The following is a description of a gene set: Mouse Gene Set: GOBP_RESPONSE_TO_OXYGEN_GLUCOSE_DEPRIVATION species: Mus musculus Any process that results in a change in state or activity of a cell or an organism (in terms of movement, secretion, enzyme production, gene expression, etc.) as a result of the deprivation of oxygen and glucose., and this is the list of marker genes: Acvr2a, Map1lc3a, Parp2, Sox2, Bnip3 (BCL2/adenovirus E1B interacting protein 3), Nppc, Inhba, Zeb2, Becn1, Dram1, Mapk8